The following is a description of a gene set: species: Homo sapiens The chemical reactions and pathways involving GDP-mannose, a substance composed of mannose in glycosidic linkage with guanosine diphosphate. Human Gene Set: GOBP_GDP_MANNOSE_METABOLIC_PROCESS, and this is the list of marker genes: GMDS, DPM1 (dolichyl-phosphate mannosyltransferase subunit 1, catalytic), GUK1, MPI, HK1, GMPPB, GMPPA, SLC35C1, PMM2, GFUS, PMM1